The following is a description of a gene set: Human Gene Set: WP_NAD_METABOLISM_SIRTUINS_AND_AGING studied in species Homo sapiens NAD metabolism, sirtuins and aging, and this is the list of marker genes: FOXO1, NFKB1, TFAM, NAMPT, SIRT1, PPARG, ROS1, PARP1, FOXO3, SIRT3, HIF1A